Given this list of marker genes JAML, MMP12, B4GALT1 (beta-1,4-galactosyltransferase 1), LRG1, LACRT, WNT7A, FGF10, ODAM, FZD7, CLDN1, here is a description of the gene set: Human Gene Set: GOBP_POSITIVE_REGULATION_OF_EPITHELIAL_CELL_PROLIFERATION_INVOLVED_IN_WOUND_HEALING Any process that activates or increases the rate or extent of epithelial cell proliferation, contributing to the restoration of integrity to a damaged tissue following an injury. species: Homo sapiens